The following is a description of a gene set: studied in species Homo sapiens Monocyte-derived dendritic cells (DC) and macrophages (MΦ) generated in vitro from the same individual blood donors were exposed to five different pathogens, and gene expression profiles were assessed by microarray analysis. Responses to Mycobacterium tuberculosis and to phylogenetically distinct protozoan (Leishmania major, L. donovani, Toxoplasma gondii) and helminth (Brugia malayi) parasites were examined, each of which produces chronic infections in humans yet vary considerably in the nature of the immune responses they trigger. Human Gene Set: GSE360_L_DONOVANI_VS_L_MAJOR_DC_UP from publication Chaussabel D, Semnani RT, McDowell MA, Sacks D, Sher A, Nutman TB (PMID 12663451) Genes up-regulated in comparison of dendritic cells (DC) exposed to L. donovani versus DCs exposed to L. major., and this is the list of marker genes: FOXA1, POU1F1, FGR, TAF1B, LARGE1, TOMM70, PDE6B, ACTG2, ATP2B3, MASP1, PI3 (NCBI Gene Id 5266), GTF3C2, CCSER2, USH2A, PWP1, MAP2K5, CD33, ATXN2L, CYFIP1, SEC23IP, DIO1, WDFY3, MCM3AP, PHF20, TEP1, CEP104, DICER1, CYP3A7, TPD52L1, PDE6G, SLC4A7, KMT2A (lysine methyltransferase 2A), ECM2, FDFT1, SYCP2, NHP2, SYT1, SELE, MFAP3, PDE2A, DNAH17, NEMF, NBR1, GATB, ATG12 (autophagy related 12), CDK20, NR1H3, NAT8, PRKD2 (NCBI Gene Id 51519), FGF12, DGKZ, BHLHE40, MEGF6, BMP10, ECE1, STT3A, WNT4, OPHN1 (oligophrenin 1), HTR2C, MYF5, SLC18A2, LILRA4, TELO2, SLC9A1, RAG1, CCNT1 (cyclin T1), DCT, TRO, FCGBP, EIF4H, SIX6, SPINK2, GGCT, FCHO1, ETFA, TET3, DMXL1, UNC5B, DLGAP4, NUDT3, NT5C2 (NCBI Gene Id 22978), CAMLG, RAB6A, UBE2B, EXOSC2, SERPINB13, RAB40AL, S100B, XDH, FRG1, PIK3CG, HOXA1, CDYL, YJU2, LPO (NCBI Gene Id 4025), NPR3, BRME1, ABCC5, PLAGL1, ALDH3A2 (aldehyde dehydrogenase 3 family member A2), CYP11B1, OGT, CRYM, DDX21, TCAF1, RAB4B, SGCA, SPINK5, SLC25A24, PRKAB2, BRS3, ITPKA, TARBP2, FADS1, HDAC9, KLRC4, SMYD2, MMP11, REG1B, NFIA, HTRA1, KDELR3, PCDHGA8, POLA1, ACLY, FAM3C, CPSF4, ZIC2, TRPC3, EIF2S1, PRL (prolactin), GAB2, ISLR, TEAD3, ROR2, BTG2, THAP3, TMCC1, STX2, DOCK10, CETP, P2RY11, HIC2, USP22, MPPE1, CACNA1C, SPC25, ASS1, TRPV6, CGA, MAN2C1, SRGAP3, OR2F1, ANXA3, MLEC, SNRNP35, PLCE1, DAPK3, SMYD5, GNMT, LIF, SEMG2 (semenogelin 2), PRPF40A, RPL18, MTHFD2, GAS2, PSMC2, MYRF, GH2, CTSA (cathepsin A), DDHD2, MAD2L1, AGPS, TNN, IGF1, AGR2, FAM131B, TLR3, KRT16, BBC3, CPE, GFUS, IMP4, PIP5K1B, ATRX, RRP7A, PUM3, GUCA1A, BFSP2, SLC25A5, SMTN, CMKLR2, NEDD4L, PNMA2, ALAS2, POLE3, PEX13, TM7SF2, GRIN1, MGAT4C